The following is a description of a gene set: Reactome Pathway: Defective pro-SFTPC causes SMDP2 and RDS species: Homo sapiens part of: Diseases associated with surfactant metabolism Pulmonary surfactant-associated protein C (SFTPC), amongst other roles, is a component of surfactant, a surface-active film that helps reduce surface tension in alveoli. Defects in the SFTPC gene result in protein misfolding, misrouting and/or misprocessing resulting in accumulation of partially-processed, inactive pro-SFTPC in alveoli causing cell toxicity. Defects in SFTPC can cause pulmonary surfactant metabolism dysfunction 2 (SMDP2; MIM:610913), a rare lung disorder due to impaired surfactant homeostasis characterised by alveoli filling with floccular material. Cellular responses to the misfolded pro-SFTPC products include ER stress, the activation of reactive oxygen species and autophagy. Excessive lipoprotein accumulation in the alveoli results in a form of respiratory distress syndrome in premature infants (RDS; MIM:267450)., and this is the list of marker genes: SFTPC